Given this list of marker genes HES6, BLOC1S5, PPT1, ZFYVE19, KDM8, PSMD13, NUDT1, ASH2L, RPAP3, NIPSNAP1, NXT2, LDLR, MVK, CMAHP, CHAF1B, OLA1, ELMOD3, DUT, DNAJC6, RTKN, SCAMP1, SAAL1, C16orf54, GRPEL1, NDUFB4, MAP2K6, RNF141, DECR2, EIF2B1, P2RX1, RFC5, GTF2F1, MTG1, TIMM17A, RABL3, MTRF1, HACL1 (2-hydroxyacyl-CoA lyase 1), CFAP36, OTUB1, TMEM30A, FDPS, NUDCD2, NUP42, MOSPD2, ABCA1, PPP1R7, GAL3ST3, TNFSF10, MSMO1, HMGCL, FDFT1, UXT, TUBG1, PTPRA, TFPI, RNF130, ECHDC1, TSPO, GTF2E1, TAB1, ANP32A, TXNDC15, DCLRE1B, GINS1, IL18R1, TUBB2A, DYNC2LI1, PFKFB1, TAFAZZIN, ILVBL, MED10, GPSM2, INSIG1, PDZRN3, LMNTD1, POLR2G, NEXMIF, OSGEP, MNAT1, TRDMT1, PTPRN, LHPP, MFGE8, CDC6, TULP1, POLR2D, WDR35, TBC1D19, ARL2, MXI1, SUDS3, ISOC1, METTL21A, GSS, SRL, HMGCS1, GSTP1, DHRS3, ZFAND1, HAGH, NUDT14, RANBP1, HIBADH (NCBI Gene Id 221893), CALM3, MED30 (mediator complex subunit 30), COX15, FLG2, ENTPD5, KHK, EMP3, SEPTIN8, NDUFC1, TUBB2B (tubulin beta 2B class IIb), STX18, N6AMT1, SUMF1, HGSNAT, ADCK1, ACAT2 (NCBI Gene Id 39), NEIL1, IFT22, CLNS1A, MKRN2, SUMO2, NXT1, RAB11A (RAB11A, member RAS oncogene family), NMI, NUBP1, CEACAM1, MARCKS, HINT3, IFT27, PLIN3, CYC1, MRPL36, RHBDD1, PRPS1, CENPQ, CAB39L, FBXL12, ATP5IF1, NUP107, SLC29A3, SNAP47, RFC3, PCCB, NME3, ACAT1, LSM4, SPG21, SHLD2, GGTA1, TNFAIP8L2, ANAPC13, NAP1L2, CETN2, CRYL1, GPN3, NUDT15, DGCR6, AARSD1, FDX1, SLC25A24, MR1, SLC25A11, CDK19, TRAPPC2L, SUMO3, here is a description of the gene set: CD4+ T helper lymphocytes that express interleukin-17 (Th17 cells) have critical roles in mouse models of autoimmunity, and there is mounting evidence that they also influence inflammatory processes in humans. Genome-wide association studies in humans have linked genes involved in Th17 cell differentiation and function with susceptibility to Crohn’s disease, rheumatoid arthritis, and psoriasis1-3. Thus, the pathway towards differentiation of Th17 cells and, perhaps, of related innate lymphoid cells with similar effector functions4, 5, is an attractive target for therapeutic applications. Mouse and human Th17 cells are distinguished by expression of the retinoic acid receptor-related orphan nuclear receptor RORγt, which is required for induction of IL-17 transcription and for the manifestation of Th17-dependent autoimmune disease in mice6. By performing a chemical screen with an insect cell-based reporter system, we identified the cardiac glycoside digoxin as a specific inhibitor of RORγt transcriptional activity. Digoxin inhibited murine Th17 cell differentiation without affecting differentiation of other T cell lineages and was effective in delaying the onset and reducing the severity of autoimmune disease in mice. At high concentrations, digoxin is toxic for human cells, but non-toxic synthetic derivatives, 20,22-dihydrodigoxin-21,23-diol (Dig(dhd)) and digoxin-21-salicylidene (Dig(sal)), specifically inhibited induction of IL-17 in human CD4+ T cells. Using these small molecule compounds, we demonstrated that RORγt is imporant for the maintenance of IL-17 expression in mouse and human effector T cells. These data suggest that derivatives of digoxin can be used as chemical probes for development of RORγt-targeted therapeutic agents that attenuate inflammatory lymphocyte function and autoimmune disease. species: Homo sapiens from publication Huh JR, Leung MW, Huang P, Ryan DA, Krout MR, Malapaka RR, Chow J, Manel N, Ciofani M, Kim SV, Cuesta A, Santori FR, Lafaille JJ, Xu HE, Gin DY, Rastinejad F, Littman DR (PMID 21441909) Genes down-regulated in polarizing CD4 Th17 cells: wildtype versus RORC knockout. Human Gene Set: GSE27241_WT_VS_RORGT_KO_TH17_POLARIZED_CD4_TCELL_DN